The following is a description of a gene set: Human Gene Set: GSE7831_CPG_VS_INFLUENZA_STIM_PDC_1H_UP studied in species Homo sapiens Genes up-regulated in plasmacytoid dendritic cells (1h): CpG oligodeoxynucleotide 1826 versus influenza virus infection. CpG 1826 binds to Toll-like receptor (TLR)9, whereas influenza virus PR8 activates pDC via TLR7. Differential stimulation of pDCs is expected to result in unique activation mechanism(s) leading to a different phenotypically and functionally matured pDC We used microarrays to detail the global programme of gene expression underlying the maturation process of pDC activated with CpG 1826 and influenza virus PR8. We identified a distinct expression profile of upregulated immunomediators. from publication Iparraguirre A, Tobias JW, Hensley SE, Masek KS, Cavanagh LL, Rendl M, Hunter CA, Ertl HC, von Andrian UH, Weninger W (PMID 18029397), and this is the list of marker genes: GRK6, MED23, PPIC, MYB, DEK, ZNF746, RIOK1, ADPRH, DTNB, TCEAL9, CWC15, TOP2A, CMA1, DAP, MAP3K4, SF3B1, CEL, MRPS10, SMC4, TMEM126A, LUC7L3, ZNF239, GZMB, CD96, IDE, MTRES1, ITIH5, TAL1 (TAL bHLH transcription factor 1, erythroid differentiation factor), GIMAP1, SHISA5, EIF3C, ASRGL1, RAD1, RABGAP1L, PXK, ZW10, RAD21, SNX1, FXYD5, SEC61A2, SARNP, RFLNB, RCN1, BLTP2, MSL1, IST1, ZFPM1, ITPR2, TOP2B, PFKP, S1PR4, MCAM, EDEM1, H2AZ1, MCOLN2, THOP1, IGF2R, MRPS16, CD53, DNM1L, ATG5 (NCBI Gene Id 9474), KRR1, CRCP, PEF1, GRM8, PTP4A3, IL18RAP, ANAPC5, PRKAB1, TES, TLE4, SPSB2, DIPK2A, RBM10, CAD, DLD, AK3, ABCD3, LCK, MTX2, LRP10, TRIM59, KMT2A (lysine methyltransferase 2A), BCAS2, SS18, FTSJ3, ANGPT1, BUB3, PSPH, CAVIN3, PIGX, PDHB, SUN1, TRIR, BSG, HPRT1, INPP5B, TXNDC5, ZBTB7A, LMAN2, SEMA4A, CTSE, PPP2R5A, KLHDC2, PHF5A, LANCL1, COIL, RSPH3 (NCBI Gene Id 83861), CD247, SFN, ASB6, SPTBN1, SCAF8, PIK3CD, GOLM1, C5orf34, IKBKE, VPS29, RNASEH1, IMMP1L, CD48, RNF138, ATP6V0A2, PEX6, CSE1L, RPAP3, XRCC6, ABCA1, PHC2, ETS1, SIRT3, LPIN2, PDHA1, AHNAK, CA1, GAS7, DCAF1, C8orf82, HDAC2, PIP4P2, G3BP2, VAPA, CXCR4, NAE1, KRAS, IL18R1, NFATC1 (nuclear factor of activated T cells 1), ZKSCAN1 (zinc finger with KRAB and SCAN domains 1), CA2, SMAP1, GABPA, PRADC1, HMGB3, PRKCH, PARP6, PDCD2, ERH, ARAP3, RP9, CDK11B, MEF2D, TYSND1, UBR7, SKI, FASLG, SLC27A4, FERMT3, ADORA2A, SRSF6, GOLGA4, NPTX2, PYGB, CAPN7, RNASE1, DNAJA1, CCDC117, RPRD1B, MLLT1, LIAS, KCTD9, LATS2, TEN1, NFYC, KIF3C, NAB2, CCR5, PEX5, NAB1, PUS1, MGAT2, AZI2 (5-azacytidine induced 2), NSMF, IL7R, CAVIN2, MRPS5, ORC1, LAMTOR2, PAG1, FAM220A, TMEM71